Given this list of marker genes PPP1R16A, ABI3, ANKRD13D, GRK6, RILPL1, GPS2, HSPB1, KCNE3 (potassium voltage-gated channel subfamily E regulatory subunit 3), POLR3H, LAMTOR1, PSTPIP1, RGS14, CTCF, LDLR, BRCA2, RPL13, NSA2, ICAM4, SDHAF1, USP21, NCAPH2, BOLA1 (NCBI Gene Id 51027), SRRD, VAMP5, MYO1E, LRWD1, NFIC, ST6GALNAC5 (ST6 N-acetylgalactosaminide alpha-2,6-sialyltransferase 5), TIMM13, NR1H2, MT1E, NFKBIL1, RPS14, TDP1, POLR2I, INF2, FCRLA, COA4, DALRD3, PTPRE, ANTKMT, CNP, NOCT, ATF4, IL1B, MLLT1, RAB27A, JUN, IQCE, JDP2, IFT22, POLD1, CHCHD4, ANKRD54, PICK1, TEC (NCBI Gene Id 7006), SAPCD2, MRPL12 (mitochondrial ribosomal protein L12), RNGTT, PIK3R2, ATF3, EHMT2, HSPA1A, SLC13A2, TMEM119, AARS1, TIMELESS, MALAT1, PIMREG, NCBP2AS2, TJP3, ARRDC2, DNAJC4, IGFBPL1, PTK2B, BTBD2, DHRS13, SIGIRR, ARRB2, PNKD, OVCA2, BATF, RASGEF1B, TNFAIP6, SIPA1, CARS1, DVL1, VRK3, LTBR, LMNB2, POLR2J, HGFAC, KNSTRN, COL16A1, HK2, NANS, XRCC6, CDC7, ITPRIP, ZNF862, VPS51, SNORD104, TUBB6, KAT14, FES, PRDM2, CARD11, MEGF8, RABEP1, URI1, MRPS18B, DDX23, CYTH4, NLRP3, CBFA2T3, NEIL1, CDK5RAP3, FKBP15, RIN3, ARHGAP4, GTF3C6, ADM, STUB1, HYI, OGFRL1, MED12, JMJD6 (jumonji domain containing 6, arginine demethylase and lysine hydroxylase), EIF4G3, MPG, STYXL2, SLC2A1, IRF1, BAZ1B, ANAPC4, FERMT3, SSH1, AGAP3, IL4R, ST3GAL2, RBIS, LLGL1, XIAP, CRISPLD2, TMEM160, TAMALIN, SLC7A1, CSNK1E, PTPN18, DNAJB1, TIFAB, ZFHX3, STAT6, PSRC1, SLC6A13, DAPK3, FGD2, NDUFB10, RPL36, SLC12A9, NOL12, ZNF593, CHCHD5, BORA, MATK, DBNL, CIITA, CLK3, PAM16, SLC7A6OS, PLPP2, SUPT3H, SREBF1, NSMF, SRPK2, UBAC1, PARK7, HVCN1, KMT5C, CWC22, GADD45GIP1, HAGHL, TRIP6, HSPA1B, DOHH, MAPKAPK5, DMTF1, WDR11, TCIRG1, PARP2, DDX11, NDUFS5 (NCBI Gene Id 4725), CCDC88B, MRPL17, TELO2, COA3, TUBA1B, PRMT7, ARHGAP45, ELAC2, here is a description of the gene set: Dendritic cells (DC) serve a key function in host defense, linking innate detection of microbes to the activation of pathogen-specific adaptive immune responses. Whether there is cell-intrinsic recognition of HIV-1 by host innate pattern-recognition receptors and subsequent coupling to antiviral T cell responses is not yet known. DC are largely resistant to infection with HIV-1, but facilitate infection of co-cultured T-helper cells through a process of trans-enhancement. We show here that, when DC resistance to infection is circumvented, HIV-1 induces DC maturation, an antiviral type I interferon response and activation of T cells. This innate response is dependent on the interaction of newly-synthesized HIV-1 capsid (CA) with cellular cyclophilin A (CypA) and the subsequent activation of the transcription factor IRF3. Because the peptidyl-prolyl isomerase CypA also interacts with CA to promote HIV-1 infectivity, our results suggest that CA conformation has evolved under opposing selective pressures for infectivity versus furtiveness. Thus, a cell intrinsic sensor for HIV-1 exists in DC and mediates an antiviral immune response, but it is not typically engaged due to absence of DC infection. The virulence of HIV-1 may be related to evasion of this response, whose manipulation may be necessary to generate an effective HIV-1 vaccine. Human Gene Set: GSE22589_HEALTHY_VS_SIV_INFECTED_DC_UP Genes up-regulated in monocyte-derived dendritic cells: control versus SIV infection. from publication Manel N, Hogstad B, Wang Y, Levy DE, Unutmaz D, Littman DR (PMID 20829794) species: Homo sapiens